Given this list of marker genes Cadm3, Rbms2 (RNA binding motif, single stranded interacting protein 2), Gdnf, Itpripl1, Nat8f6, Tmub1, Pcdh9, Npcd, Dock5, Pea15a, Mlec, Cldn19, Slc30a10, Mief1, Tet3, Xkrx, Usp42, Cd44, Glt8d2, Nono, Ddb1, Mapk9, Klhl26, Esr1, Mtcl2, Crlf3, Serinc5, Mprip, Maf, Mpp1, Plxna4, Antxr1, Slain2, Arhgef7, Nlgn2, Nptxr, Nr6a1, Kpna6, Fam120a, Arih2, Zfp111, Arhgef19, Ypel1, Spock2, Ptpn9, Vsnl1, here is a description of the gene set: species: Mus musculus Genes predicted to be targets of miRBase v22 microRNA mmu_miR_7032_5p in miRDB v6.0 with MirTarget v4 prediction scores > 80 (high confidence targets). Mouse Gene Set: MIR_7032_5P from publication Chen Y, Wang X (PMID 31504780)